Given this list of marker genes Gpx4, Lta4h, here is a description of the gene set: electronically inferred by orthology from the curated human pathway Reactome Pathway: Biosynthesis of D-series resolvins This event has been computationally inferred from an event that has been demonstrated in another species.<p>The inference is based on the homology mapping from PANTHER. Briefly, reactions for which all involved PhysicalEntities (in input, output and catalyst) have a mapped orthologue/paralogue (for complexes at least 75% of components must have a mapping) are inferred to the other species. studied in species Mus musculus part of: Biosynthesis of DHA-derived SPMs